The following is a description of a gene set: studied in species Homo sapiens Human Gene Set: LIAO_METASTASIS Genes up-regulated in the samples with intrahepatic metastatic hepatocellular carcinoma (HCC) vs primary HCC. A comprehensive microarray analysis of hepatocellular carcinoma (HCC) revealed distinct synexpression patterns during intrahepatic metastasis. Recent evidence has demonstrated that synexpression group member genes are likely to be regulated by master control gene(s). Here we investigate the functions and gene regulation of the transcription factor SOX4 in intrahepatic metastatic HCC. SOX4 is important in tumor metastasis as RNAi knockdown reduces tumor cell migration, invasion, in vivo tumorigenesis and metastasis. A multifaceted approach integrating gene profiling, binding site computation and empirical verification by chromatin immunoprecipitation and gene ablation refined the consensus SOX4 binding motif and identified 32 binding loci in genes with high confidence. RNAi knockdown of two SOX4 target genes, neuropilin 1 and semaphorin 3C, drastically reduced cell migration activity in HCC cell lines suggesting that SOX4 exerts some of its action via regulation of these two downstream targets. The discovery of 31 previously unidentified targets expands our knowledge of how SOX4 modulates HCC progression and implies a range of novel SOX4 functions. This integrated approach sets a paradigm whereby a subset of member genes from a synexpression group can be regulated by one master control gene and this is exemplified by SOX4 and advanced HCC.Oncogene advance online publication, 26 May 2008; doi:10.1038/onc.2008.168. from publication Liao YL, Sun YM, Chau GY, Chau YP, Lai TC, Wang JL, Horng JT, Hsiao M, Tsou AP (PMID 18504433), and this is the list of marker genes: PSMC3IP, PCNX3, NSMAF, HDAC1, MAP4K4, SH2B1, AKR1B10, MMP11, PRRC2B, PDK1, MORC2, SGSH, RHOBTB1, ARFGEF3, FBXO41, CHD7, COL1A1, LASP1, HIF1AN (hypoxia inducible factor 1 subunit alpha inhibitor), SULT1C2, PURB, TRPS1, SNRNP48, CIB2, PRR11, SLC52A2, HLA-DQA1, AMMECR1, SEMA3F, GAS5, TOX3, GLS, FOXM1, DNM1L, SMOX, FAR2P2, RAPGEF1, RACK1, DEAF1, ATAD2, SPAG4 (NCBI Gene Id 6676), TSHZ2, CARD8, DEF6, CD24P4, BCAT1, RABL6, FBLN1, ADSL, ALDOA, SORT1, GNG4, HYOU1, ATP13A2, CCL28, ITGA2, TRIP13 (NCBI Gene Id 9319), SNRPA, SNHG14, MFSD4B, DDOST, SYNCRIP, SENCR, MAGEA1, SURF2, ZNF292, CCDC93, NETO2, NSD2, TMED9, AEBP1, JMY (junction mediating and regulatory protein, p53 cofactor), WDR5, EHD2, CEP15, DNAJC6, NUMBL, ANKRD46, PTP4A3, KCTD2, ZNF239, PDCD2, SELENOM, SERINC2, DTNBP1, SOCS7, GPRC5B, DTNA, DTYMK, CEP164, TMEM201, MAP2, MFSD10, GXYLT2, NEAT1, RBIS, MSANTD3, PKIB, ZNF302, FAM50A, CSTPP1, CLTB, SERPINE2, TRAF5, ARHGEF2, PAM, BOP1, SPINT1, SNAP25, NHSL3, NDOR1, ZNF234, MAP4, OTUD3, SLC2A1, CRIM1-DT, PHPT1, PRRC2A, SEMA3C, RHOQ, SLF2, MECOM, MAP7D2, GTSE1, ARHGAP4, PKP4, MEP1A, FXYD3, SHKBP1, CBX5, DKK1, RRAGD, FHOD3, BMAL2, PHF21A, FAM171B, SLC25A24, SERPINB1, SCRIB (NCBI Gene Id 23513), MPHOSPH9, MTMR2, ALDH18A1, WFIKKN1, TMEM65, PLXNA1, DUSP22, SOAT1, INTS8, DHRS13, VPS13C, SEPTIN9, HIC2, TPD52L2, UPF3B, KIFC2, FUS, PLAGL1, RRAS, PLAG1, SOX9, ZDHHC24, GORAB, CECR2, BUB1B, SLC44A3, PTMA, MAP3K4, STOX2, VSIG10, SPINK1, TSSC4, RAVER1, USP48, TMCO4, SMPD2, ZCCHC17, MARS1, ZIC2 (NCBI Gene Id 7546), PLCB1, MEAF6, RASA4, HMGA1, MAGED4B, GAGE1, ANKRD52, TFPT, PWWP2B, SPON2, DNAJA4, SBNO1, DUSP9, DGCR2, GAS2L3, GRAMD1A, IGSF3, SLFN13, IKZF4, NUP43, SMG5, GYG1, PDE4C, RUVBL2, ALPK3, URB2, CAPG, GABBR1, FARP1, TOB2, TCIRG1, MTCL1, PIGT, UBAP2, PCLAF, CHTF18 (chromosome transmission fidelity factor 18), LRP11, REXO4, UBAP2L, NUDT14, LIMK2, IPPK, POPDC3, HPS3, BCAS4, FOXO6, GFUS, DLG5, SERPINH1 (NCBI Gene Id 89588), MROH1, MSI2, ZNF783, COL11A2 (collagen type XI alpha 2 chain), GNAS, SAP25, SSBP2, SESTD1, SLC36A1, ZNF704, MBNL1, UCHL1, SLC6A8, N4BP2L2 (NEDD4 binding protein 2 like 2), TCF3, PCSK5, MCAM, GCNT3, CA12, EFCAB2, TUBB2A, TRABD, TMCC1, NAV3, TMEM200B, CDCA7L, SHC1, HUNK, ZMYND19, MTHFD2, HSPBAP1, CCNQ, SLC7A11, GTPBP1, FLNA, CSNK1E, NPNT, OLA1, LUZP1, CBX2, VANGL1, CKMT1B, AP1S2, PLEKHG2, CCDC144NL-AS1, FERMT1, ARHGEF1, POU2AF1, ZNF777, UBE2Q2, MIR210, DGKZ, ARG2, MKNK1, USP42, CLN6, PPP1R9A, B3GNT5 (UDP-GlcNAc:betaGal beta-1,3-N-acetylglucosaminyltransferase 5, NCBI Gene Id 84002), CENPM, TBC1D13, ORAI2, TECPR1, SLC45A4, PKM, HMGB3, POMK, SLC25A19, PIDD1 (NCBI Gene Id 55367), TUFT1, FNDC3B, MCOLN3, CDCA7, ROBO1, NACA, EEF1A2, TTLL7, ASNS, ST14, ATIC, ADAMTS5, C18orf54, B3GALNT1, SLC16A7, SCAMP5, NQO1, TDG, CDKN1C, PAQR5, CTSC, CCEPR, EZH2, PDGFA, ZC3H3, MAPK13, PAFAH1B3, SLC22A15, BCL11A, HRAS, CTHRC1, FAM199X, BCORL1 (BCL6 corepressor like 1), NEIL3, SOX4, CCDC97, HOXA5, KCNQ1, CDK13, SCN8A, TAF3, SLC39A10, ADAM33, DMKN (dermokine), CTNND2, PRPF31, STRBP, MYLIP, SPRING1, TGFB2, MTHFD1L, KRT23, NRP1, PLD1, MYBL2, GRK6, TOR1AIP2, TFAP2C, RCAN3, ZP3 (zona pellucida glycoprotein 3), GNPDA1, TMEM165, CHML, FABP5, IRAK1, NUF2, FBLIM1, ESS2, ANKRD10, MAP1B, FLCN, MALAT1, TMSB10, KIF2A, PNKP, MRS2, MRTO4 (NCBI Gene Id 94394), AGRN, NPAS2 (neuronal PAS domain protein 2), ASRGL1, HES4, FAM110A, ZNF432, SF3A2, BARD1, IGF2BP3, CABYR, MMD (monocyte to macrophage differentiation associated), RAD54L, HJURP, HPS1, ASAP1, CDC7, VCAN, GPR107, SLC29A4, G6PD, YARS1, PDZK1IP1, MAPK3, PFKFB4, ECT2, HKDC1, SLC25A36, DLGAP4, TKT (NCBI Gene Id 7086), KCNH2, ZFP41, ITGAV, BAMBI, NFIA, TWIST1, ASPH, TRPC1, TAX1BP3, VGLL4, IFRD1, MILIP, KIAA0513, SUSD4, TPM2, DENND1A, WDR54, MMP12, PPM1F, RNF115, GPX8, CCNE1, CHD2, KIF18B, RAD54B, RCC2, CKAP4, PTGFRN, COLEC12, ZNF789, CHFR, DPP3, MYEF2, TNPO1 (transportin 1), ACTN4, BIRC5, ATXN2L, ZNF765, SAC3D1, PACSIN2, DENR (density regulated re-initiation and release factor), DGKH, DNAAF9, SSBP4, ZNF532, CAPN10, CREB3L1, ENO2, SPINT1-AS1, DDHD1, TRAPPC4, TEAD2, PLBD2, STK39, RRP7A, NOL3, PDIA4, PRXL2B (NCBI Gene Id 127281), PGF, PUSL1, WDFY2, NUB1, NIBAN2, PTGR1, SLC39A4, TTLL4, RNF145, PTGES, SLC2A6, SPTBN1, PTPRM, ZNF618, ARFGAP1, EMC1, ZNF736, GDI1, GLDN (gliomedin), E2F1, TMEM237, LLGL1 (NCBI Gene Id 3996), LRPPRC, NICOL1, SNAPC4 (small nuclear RNA activating complex polypeptide 4), CBX6 (chromobox 6), ZC3HAV1, ANXA2, RBM10, PLP2, BICDL1, PTPA, HOXD8, ENAH, PTPN14 (protein tyrosine phosphatase non-receptor type 14), VSIG10L, PLXNC1, THEM4, ITPR3, SOHLH2, PHF19, MICALL1, ZNF827, DBN1, BRD9, FOXQ1, KLHL29, CPSF1, AGTRAP, ZMYM3, B3GAT3, TRIP10, UBE2O, SZRD1, SCFD1, BOLA2, SLC25A29, SMARCE1, PTK2, LAMA5, JRK, PPIL2, NUPR1 (nuclear protein 1, transcriptional regulator), TNIP2, UCP2, NFKBIB, TACC3, PES1, MACROD2, IGF2BP2, NRCAM, COL1A2, RRP12, PYCR3, MXD1, DNAJC10, NEMP1, DDIT4, DDX25, FIGN, GBP2, LAMB1, CD109